The following is a description of a gene set: species: Homo sapiens Genes up-regulated in peripheral blood mononuclear cell vaccinated vs candin placebo in infants (4-6m) (BCG-primed) after exposure to Modified Vaccinia Ankara (MVA) virus vaccine vector, time point 28D Human Gene Set: MATSUMIYA_PBMC_MODIFIED_VACCINIA_ANKARA_VACCINE_AGE_4_6MO_VACCINATED_VS_CANDIN_PLACEBO_BCG_PRIMED_28DY_UP from publication Matsumiya M, Harris SA, Satti I, Stockdale L, Tanner R, O'Shea MK, Tameris M, Mahomed H, Hatherill M, Scriba TJ, Hanekom WA, McShane H, Fletcher HA (PMID 24912498) BACKGROUND: Tuberculosis (TB) remains a global health problem, with vaccination likely to be a necessary part of a successful control strategy. Results of the first Phase 2b efficacy trial of a candidate vaccine, MVA85A, evaluated in BCG-vaccinated infants were published last year. Although no improvement in efficacy above BCG alone was seen, cryopreserved samples from this trial provide an opportunity to study the immune response to vaccination in this population. METHODS: We investigated blood samples taken before vaccination (baseline) and one and 28 days post-vaccination with MVA85A or placebo (Candin). The IFN-gamma ELISpot assay was performed at baseline and on day 28 to quantify the adaptive response to Ag85A peptides. Gene expression analysis was performed at all three timepoints to identify early gene signatures predictive of the magnitude of the subsequent adaptive T cell response using the significance analysis of microarrays (SAM) statistical package and gene set enrichment analysis. RESULTS: One day post-MVA85A, there is an induction of inflammatory pathways compared to placebo samples. Modules associated with myeloid cells and inflammation pre- and one day post-MVA85A correlate with a higher IFN-gamma ELISpot response post-vaccination. By contrast, previous work done in UK adults shows early inflammation in this population is not associated with a strong T cell response but that induction of regulatory pathways inversely correlates with the magnitude of the T cell response. This may be indicative of important mechanistic differences in how T cell responses develop in these two populations following vaccination with MVA85A. CONCLUSION: The results suggest the capacity of MVA85A to induce a strong innate response is key to the initiation of an adaptive immune response in South African infants but induction of regulatory pathways may be more important in UK adults. Understanding differences in immune response to vaccination between populations is likely to be an important aspect of developing successful vaccines and vaccination strategies. TRIAL: ClinicalTrials.gov number NCT00953927., and this is the list of marker genes: IFI35, CCL8, WARS1, GBP1, FBXO6, CXCL10, GBP4, CXCL9, STAT1, PARP9